The following is a description of a gene set: studied in species Homo sapiens Any process that modulates the rate, frequency or extent of mesonephros development. Mesonephros development is the process whose specific outcome is the progression of the mesonephros over time, from its formation to the mature structure. The mesonephros is an endocrine and metabolic organ that filters the blood and excretes the end products of body metabolism in the form of urine. Human Gene Set: GOBP_REGULATION_OF_MESONEPHROS_DEVELOPMENT, and this is the list of marker genes: SIX1, HNF1B, GATA3, GDNF, SIX4